Given this list of marker genes PPT1, ATP6V0A4, MCTP2, SNAPIN, ATP8A1, ATP6V1E1, SV2C, ZNRF1, PRRT1 (NCBI Gene Id 80863), OTOF, RAB3B, PHF24, CLTA, ABCC8, SLC6A17 (NCBI Gene Id 388662), SV2A (synaptic vesicle glycoprotein 2A), DTNBP1, RAB11A, ATP6AP2, CLCN3, SYN1, GRIA1, SYNPR, DNAJC5, DYSF, PHAF1, ATP6V1A, PRRT2, SYPL2, GPR151, SYT2, TMEM163 (transmembrane protein 163), SLC35F1, STX1A, BSN, UNC13B, OPRD1, SLC17A8, RAB11B, DNM1L, PTPRN2, SYN3, VAMP1, RPH3A, RAB3A, DOC2A, SYT4, ATP6V1G3, ATP2B1, SLC18B1, SV2B, SYNGR1, SLC17A5, PRKN, SYT6, ATP6V1G2, STX6, SYT5, KIF1B, SLC18A2, ATP6V1C1, ATP6V1D, SYT1, TAFA4, SLC35D3, STX10, SCAMP5, CALM3, UNC13C, SLC18A1, SLC5A7, ATP6V1B1 (NCBI Gene Id 525), ATP6V0E2, ATP6V1B2, DGKI, SYN2, SLC32A1, SYNDIG1, FER1L5, SYNGR3, SYPL1, ANP32E, ICA1, ATP6V0D1, BTBD8 (BTB domain containing 8), BIN1, SYT8, SYT9, RAB5A, SLC4A8, SEPTIN8, AMPH, OPRK1, ATP6V1H, GABRA2, VAMP2, SYNGR4, ATP6V0A1, SLC17A6, SLC6A9, STX12, SNCA, SYNGR2, SLC35G2, WFS1, SLC30A3, RAB27B, ATP6V0C, SEMA4C, RAB7A, SYP, CBARP, TPRG1L (tumor protein p63 regulated 1 like), SYT7, CLTB, RAB5B, MCTP1, LAMP5, ATP6AP1, ATP6V1F, SLC9B2, RAB26, BORCS5, LRRK2, CPLX3, STX16, UNC13A, ATP6V1G1, RAC1, PTPRS, SLC18A3, SYT13, SLC17A7, SLC6A2, DMXL2, DRD2, MYOF, SCAMP1, ARPC2, BCL2L1, SYT12, ATM, SVOP, here is a description of the gene set: The lipid bilayer surrounding a synaptic vesicle. Human Gene Set: GOCC_SYNAPTIC_VESICLE_MEMBRANE studied in species Homo sapiens